The following is a description of a gene set: Human Gene Set: GOCC_PTW_PP1_PHOSPHATASE_COMPLEX A protein serine/threonine phosphatase complex that contains a catalytic subunit (PPP1CA, PPP1CB or PPP1CC) and the regulatory subunits PPP1R10 (PNUTS), TOX4 and WDR82, and plays a role in the control of chromatin structure and cell cycle progression during the transition from mitosis into interphase. species: Homo sapiens, and this is the list of marker genes: PPP1CB, WDR82, TOX4, PPP1R10, PPP1CC, PPP1CA (NCBI Gene Id 5499), PPP1R12A